The following is a description of a gene set: Mouse Gene Set: GOBP_REGULATION_OF_POTASSIUM_ION_EXPORT_ACROSS_PLASMA_MEMBRANE species: Mus musculus Any process that modulates the frequency, rate or extent of potassium ion export across the plasma membrane., and this is the list of marker genes: Kcnh2, Kcne3, Wnk4, Nppa, Kcnip2, Dlg1, Ano6, Kcne5